Given this list of marker genes Reep2, Rgs21, Itpr3, Tas1r2, Tas1r3, Gnat3, Calhm1, here is a description of the gene set: Mouse Gene Set: GOBP_SENSORY_PERCEPTION_OF_SWEET_TASTE studied in species Mus musculus The series of events required to receive a sweet taste stimulus, convert it to a molecular signal, and recognize and characterize the signal. This is a neurological process.